Given this list of marker genes DDX28, RIT1, CRIP3, FICD, LRRC14, ZNF708, MIS18A (NCBI Gene Id 89756), FEM1A, FCRLA, FAM111A, CCDC71, TNFRSF13B, AMPD3 (adenosine monophosphate deaminase 3), ILF2, SPNS3, PLIN2, PRUNE1 (prune exopolyphosphatase 1), ZBTB5, CPT2, IL4I1, ZNF790, GPR146, IRGM, DNAJC9, RALBP1, TRIM34, STARD8, AKAP12, ANAPC4, HSH2D, EPS8, EBP, SLC25A11, GPR155, CDC16, MFAP3, CLPTM1L, CTNNA1, FOXP1, RFC1, MED19, KLF13, SNX9, PRSS12, PPP1R18, NKIRAS2, VWA7, SASH3, C16orf54, TMEM258, MOGS, CLDN10, PTPRCAP, MRGPRE, CDK2AP2, FRMD6, CNPY2, FAM120AOS, CPSF7, LIPT1, ZNF560, TMED9, IREB2, IPO13, ADD1, RAD52, KYAT1, IL31, TRUB2, ZNF22 (zinc finger protein 22), NRM, RNF130, IL16, RNF31, ECD, PIP5K1B, STRN4, TNS3, SLC25A53, PIK3IP1, WLS, PNPT1, INPP1, PARD6G, BTLA, MRPL47, BTD, SLC37A4, COMMD5, CHMP6, STK16, SMPD1, SLC44A2, HTATSF1, NIBAN3, C11orf68, NADK, AIDA, SSBP2, OXSM, PDK2, OPA1, ZFP41, TRAF6, MTG2, CD53, ZNF217, POLR3H, SELL, CTU1, KBTBD11, SLC14A1, PDE2A, C1orf174, LPAR6, ZNF563, C2orf68, BMPR2, RPP14, TRMT44, PLEK2, STING1, OTULINL, ZMYND11, EPHX1, PHB2, SLC44A3, TMEM126B, SREK1IP1 (SREK1 interacting protein 1), MAGI3, EXOC8, ULK3, PWP2, INSR, PRRC1, TIMM21, PRDX5, PEX10, LYRM9, H2BC13, GDPGP1, ENTREP3 (endosomal transmembrane epsin interactor 3), ZYX, CARD6, TMEM106B, TMEM181, STARD3, ZSCAN20, REEP5, PMEL, CAST, C18orf21, SDC4, CARNS1, COA3 (cytochrome c oxidase assembly factor 3), CIZ1, CSTF1, IFIT1, SNAPIN, PDE7A, ARGLU1, TMEM184C, NDUFAF1, TOR4A, TCFL5, SNX2, CDC42SE1, ZDHHC7, CD79A, NSMCE4A, DAXX, COLGALT1, ARPC5L, SESN1, TMEM109, DNAJC28, DSTYK, SCAMP3, DOCK3, SLAMF9 (NCBI Gene Id 89886), MTMR9, MAPK3, CYFIP2, RPN1, NAGLU, RNF139, PPP1CC (NCBI Gene Id 5501), SLC28A2, TLR1, C7orf25, MTURN, DIRAS2, KTI12, MAP3K2, CNN3, ARHGDIB, ARRDC1, STARD5, SNN, GPAT3, here is a description of the gene set: from publication Lang R, Pauleau AL, Parganas E, Takahashi Y, Mages J, Ihle JN, Rutschman R, Murray PJ (PMID 12754506) species: Homo sapiens Genes down-regulated in macrophages treated by IL6 for 100min: wildtype versus SOCS3. Effects of SOCS3 on the transcriptional response of bone marrow-derived macrophages to IL-6. Fetal liver cells from SOCS3+/+ or SOCS3-/- embryos were used to reconstitute recipient mice. Donor derived bone marrow from these mice was differentiated to macrophages. Macrophages were either unstimulated, or stimulated for 100 or 400 minutes with 10 ng/ml IL-6. Human Gene Set: GSE411_WT_VS_SOCS3_KO_MACROPHAGE_IL6_STIM_100MIN_DN